The following is a description of a gene set: studied in species Homo sapiens Genes predicted to be targets of miRBase v22 microRNA hsa-miR-338-3p in miRDB v6.0 with MirTarget v4 prediction scores > 80 (high confidence targets). from publication Chen Y, Wang X (PMID 31504780) Human Gene Set: MIR338_3P, and this is the list of marker genes: KCNA4, SRGAP3, CACNB4, STAG2, PAGE5, TERF2, CNOT6, KCND2, FKBP1A (NCBI Gene Id 2280), ZNF483, ZBTB18, CPEB3, CCNT2, CELSR2 (cadherin EGF LAG seven-pass G-type receptor 2), SLC2A10, ZBTB43, MSL2, APCDD1, ADAMTS6, DMRT2, UBLCP1, FAS, IDNK (NCBI Gene Id 414328), CEACAM6, HDAC9, ORC4, CC2D2B, FOS, THBS1, PPP4R1, CYP27B1, CAMK2G, ZNF493, SALL1, SLC39A14, CBFB, AAK1, VAPB, TMCC3, FUS, PCGF3 (NCBI Gene Id 253443), CBL, PIP5KL1, NTPCR, TAX1BP3, NLRP2B (NLR family pyrin domain containing 2B), NOL4, TPH2, ABCC12, DUSP16, TGOLN2, CADM2, MAP2, RHO, FGFR2, DSC3, SEC61A2, FGF2, VPS53, NIPSNAP1, TBL1XR1, ARHGEF37, B4GALT7, SEPTIN8, PREX2, ZBTB10, ZBTB39, COPS4 (COP9 signalosome subunit 4), SLC25A20 (NCBI Gene Id 788), RNF144A, ZFAND2B, KCNC2, PTEN, TBC1D15 (TBC1 domain family member 15), HIF1A, SUSD6, PRRC2C, PLA2G3, PTPN12, MYPN, MS4A6E, FAAH2, TAF1, ARGLU1, RAB14, INTS6L, AKAP12, TRIM33, SEMA6D, PVALB, LARP4, ZFHX4, CBLN3, UBE2Q1, TIMP2, FBXW7, NNT, TNFRSF1B, UBFD1, SURF1, SNX18, THSD7A, ARMCX3, C16orf87, B4GALT3, GNAQ, MTUS1, MYT1L, RAB30, CNP, DCAF12, NRP1, MYH15, SDCBP2, PHF20L1, CLASP2, RSL24D1, KCNG4, HCN1, CAMTA1, STK32C, ADGRA2, SEPSECS, SLC35F5, NIF3L1, MTCL1, PPP2R5E, F8, ETS1, RIN2, WNK4, RGS7, ZNF215, LGALSL (NCBI Gene Id 29094), MAFB, SV2A, ACTR2, CFHR5, RWDD1, DAP3, KNOP1